The following is a description of a gene set: Human Gene Set: GOBP_CELL_CELL_JUNCTION_MAINTENANCE studied in species Homo sapiens The maintenance of junctions between cells., and this is the list of marker genes: CLDN3, INAVA, F2RL1, WHRN, NLGN2, FERMT2, F2R, CSF1R, CD177, KIFC3, CNTNAP1 (contactin associated protein 1), MYADM, TJP1, MTSS1, PKP1, PLEKHA7, PARD6A, DSC1, KIRREL1, CAMSAP3, PRTN3